Given this list of marker genes ANAPC1, UBE2E1, CDC26, FZR1, ANAPC10, ANAPC16, SKP2, UBE2S, E2F1, CDC16, ANAPC11, CCNE1, CDC23, CDK6, UBE2C, CDK2, CCND2, CDKN1B, UBE2D1, TFDP1, ANAPC5, CCND3, ANAPC2 (NCBI Gene Id 29882), TFDP2, E2F3, CCNE2, CDC27, E2F2, CDK4, CCND1 (cyclin D1), ANAPC15, ANAPC4, ANAPC7, CDKN1C, CDKN1A, RB1, here is a description of the gene set: Reactome Pathway: Aberrant regulation of mitotic cell cycle due to RB1 defects RB1 was the first tumor suppressor gene discovered. Bi-allelic loss of function of the RB1 gene, located at the chromosomal band 13q14, is the underlying cause of both familial and sporadic retinoblastoma, a pediatric eye cancer. Besides retinoblastoma, carriers of germline RB1 mutations are predisposed to an array of other cancers, called second primary tumors, such as pinealoblastoma, osteosarcoma, leiomyosarcoma, rhabdomyosarcoma and melanoma.<br><br>Inactivating somatic mutations in the RB1 gene are frequent in bladder cancer (Cancer Genome Atlas Research Network 2014), osteosarcoma, ovarian cancer, small-cell lung carcinoma, liver cancer and esophageal cancer.<br><br>The vast majority of RB1 mutations in cancer represent complete genomic deletions or nonsense and frameshift mutations that are predicted to result in null alleles. Missense mutations are rare and usually result in partially active RB1 mutants. Functionally characterized RB1 missense mutations and inframe deletions mostly affect pocket domains A and B and the nuclear localization signal (NLS). RB1 missense mutations reported in cancer are, however, scattered over the entire RB1 coding sequence and the molecular consequences of the vast majority of these mutations have not been studied.<br><br>The RB1 protein product, also known as pRB or retinoblastoma protein, is a nuclear protein that plays a major role in the regulation of the G1/S transition during mitotic cell cycle in multicellular eukaryotes. RB1 performs this function by binding to activating E2Fs (E2F1, E2F2 and E2F3), and preventing transcriptional activation of E2F1/2/3 target genes, which include a number of genes involved in DNA synthesis. RB1 also regulates mitotic exit by acting on SKP2, a component of the SCF E3 ubiquitin ligase complex. RB1 facilitates degradation of SKP2 by the anaphase promoting complex/cyclosome (APC/C), thus preventing SKP2-mediated degradation of the cyclin-dependent kinase inhibitor CDKN1B (p27Kip1). RB1-dependent accumulation of p27Kip1 plays an important role in mitotic exit and RB1-mediated tumor suppression.<br><br>In addition to its role in regulation of the G1/S transition and mitotic exit, RB1 also performs other, non-canonical, functions, such as its role in the maintenance of genomic stability, which is linked to its role in chromosome condensation during mitotic prophase. The impact of RB1 mutations on these E2F-independent functions, which are still important for RB1-mediated tumor suppression, has been poorly studied. species: Homo sapiens part of: Diseases of mitotic cell cycle